Given this list of marker genes Tcf7l1, Epb41l5, Chrd, Frs2, Ripply1, Tdrkh, Tdrd6, Tbx6, Tdrd7, Smad6, Mesp2, Tmed2, Tifab, Smad2, Ptch1, Chrdl1, Tasor, Fzd5, Pld6, Gdf3, Kdm6a, Nrarp, Peg12, C2cd3, Lhx1, Smad4, Otx2, Tdrd1, Nckap1, Wnt7a, Tdrd5, Wnt5a, Tbx3, Ctnnb1, Frat1 (NCBI Gene Id 14296), Ripply2, Neurog1 (NCBI Gene Id 18014), Wt1, Cited1, Foxa2, Mesp1, Cobl, Cripto (NCBI Gene Id 235635), Pcsk6, Stil, Wnt1 (NCBI Gene Id 22408), here is a description of the gene set: Mouse Gene Set: GOBP_EMBRYONIC_AXIS_SPECIFICATION studied in species Mus musculus The establishment, maintenance and elaboration of a pattern along a line or a point in an embryo.